Given this list of marker genes GJA1, SLC15A1, SLC25A39, SLC25A40, SLC15A2, ABCC1 (ATP binding cassette subfamily C member 1 (ABCC1 blood group)), ABCC5, SLC13A3, SLC7A11, ABCC4, here is a description of the gene set: Human Gene Set: GOBP_TRIPEPTIDE_TRANSMEMBRANE_TRANSPORT The directed movement of a tripeptide across a membrane by means of some agent such as a transporter or pore. A tripeptide is a compound containing three amino acids linked together by peptide bonds. studied in species Homo sapiens